The following is a description of a gene set: Genes specifically up-regulated in pediatric acute lymphoblastic leukemia (ALL) patients by mercaptopurine and low-dose methotrexate (LDMTX). Human Gene Set: CHEOK_RESPONSE_TO_MERCAPTOPURINE_AND_LD_MTX_UP from publication Cheok MH, Yang W, Pui CH, Downing JR, Cheng C, Naeve CW, Relling MV, Evans WE (PMID 12704389) To elucidate the genomics of cellular responses to cancer treatment, we analyzed the expression of over 9,600 human genes in acute lymphoblastic leukemia cells before and after in vivo treatment with methotrexate and mercaptopurine given alone or in combination. Based on changes in gene expression, we identified genes that accurately discriminated among the four treatments. Discriminating genes included those involved in apoptosis, mismatch repair, cell cycle control and stress response. Only 14% of genes that changed when these medications were given as single agents also changed when they were given together. These data indicate that lymphoid leukemia cells of different molecular subtypes share common pathways of genomic response to the same treatment, that changes in gene expression are treatment-specific and that gene expression can illuminate differences in cellular response to drug combinations versus single agents. species: Homo sapiens, and this is the list of marker genes: MLLT10, GALNT1, RBM19, STK24, EFR3A, MRPL33, YY1, PRKY, TM9SF2, HTATSF1